Given this list of marker genes Ubb, Rps27a, Dag1, here is a description of the gene set: This event has been computationally inferred from an event that has been demonstrated in another species.<p>The inference is based on the homology mapping from PANTHER. Briefly, reactions for which all involved PhysicalEntities (in input, output and catalyst) have a mapped orthologue/paralogue (for complexes at least 75% of components must have a mapping) are inferred to the other species. Reactome Pathway: Regulation of expression of SLITs and ROBOs species: Mus musculus electronically inferred by orthology from the curated human pathway part of: Signaling by ROBO receptors